The following is a description of a gene set: Mouse Gene Set: BRACHAT_RESPONSE_TO_CAMPTOTHECIN_DN DNA microarrays are powerful tools for the analysis of gene expression on a genomic scale. The importance of individual regulatory events for the process under study can however not be deduced unequivocally without additional experiments. We devised a strategy to identify central regulators of cancer drug responses by combining the results of microarray experiments with efficient methods for phenotypic testing of candidate genes. We exposed murine FL5.12 pro-B cells to cisplatin, camptothecin, methotrexate or paclitaxel, respectively and analysed the patterns of gene expression with cDNA microarrays. Drug-specific regulatory events as well as intersections between different apoptotic pathways, including previously studied responses to staurosporine and interleukin-3 (IL-3) deprivation, were identified. Genes shared by at least three pathways were chosen for further analysis. Ectopic expression of three such genes, TEAP, GP49B, and Lipin1 was found to have an anti-proliferative effect on pro-B cells. Interestingly, we identified hemoglobin alpha as a strong pro-apoptotic regulator. While hemoglobin-expressing cells were growing normally in the presence of IL-3, they displayed accelerated apoptosis with similar kinetics as Bax overexpressing cells upon IL-3 removal. The pro-apoptotic effect of hemoglobin was suppressed by Bcl-2 and was characterized by enhanced stimulation of caspase activity. Genes specifically down-regulated in FL5.12 cells (pro-B lymphocyte) by camptothecin. from publication Brachat A, Pierrat B, Xynos A, Brecht K, Simonen M, Brüngger A, Heim J (PMID 12447701) studied in species Mus musculus, and this is the list of marker genes: Tubb5, Emc2, Rcn1, Fkbp3, Coro7, Hikeshi, Psat1, Gpi1, Esyt1, Pdk3, Mir223hg, Slc25a1, Ssb, Anxa4, Eno1b, Stat5a, Adprm, Bak1, Bad, Bnip3l (BCL2/adenovirus E1B interacting protein 3-like), Plac8, Ak4, Slc44a2, Ppia, Mt1, Rsu1, Ifitm3, Mia2, Sash3, Higd1a, Tax1bp1, Cdk1, Ostf1, Eno3, Hmgcs1, Anp32e, Gapdh, Rpl3, Ifitm2, Bcl2, Aldoa, Swi5, Ndufv3